Given this list of marker genes Sgta, Ap3m1, Nup155, Cav1, Gsn, Dnm1, Chmp1b2, Ap1s1, Grik5, Doc2a, Yipf5, Trappc11, Rab3gap1, Gorasp2, Tmem147, Usp50, Vti1b, Sptbn5, Rims2, Lysmd3, Spata46, Bin3, Mtss1, Tor1a, Plscr4, Lyst, Arhgap21, Tmem170, Map2k1, Als2, Yipf4, Trappc8, Atp8b1, Esyt2, Snx3, Spaca1, Golga2, Ncln, Tlcd1, Lnpk, Optn, Cog1 (component of oligomeric golgi complex 1), Tango2, Prkd1, Acrbp, Epb41l3, Ehd3, Pla2g3, Pacsin1, Emc2, Tmem33, Tlcd2, Snx9, Dym, Rfx2, Pi4k2b, Cog7, Plec, Ap5z1, Lamtor1, Gsdmd, Clasp2, Abcd2, Aqp11, Abca7, Vmp1, Gak, Tmem201, Pheta2, Rab1b, Rab8a, Rtn3, Vti1a, Sh3gl2, Rab2b, Washc5, Stx19, Asap1, Serinc3, Vps11, Ndel1, Pals1, Tmf1, Snap47, Sypl2, Plscr2, Agfg2, Cul7, Ndrg1, Lmna, Gcc2, Reep2, Garin1b, Mapk3, Tmed7, Atl2, Reep3, Rtn1, Ank2, Prkn, Osbpl2, Fhdc1, Slc35d3, Tmed11, Sqstm1, Tmed5, Stx7, Mia3, Jagn1, Tmprss12, Vdac2, Myrf, Vcpip1 (valosin containing protein (p97)/p47 complex interacting protein 1), Cdk1 (NCBI Gene Id 12534), Abca1, Ap1s3, Polr2m, Cylc1, Tmem41b, Chmp5, Nomo1, Sec31a, Trim72, Chmp1a, Banf1, Myh9, Izumo1r, Myh10, Snx18 (NCBI Gene Id 218636), Tbpl1, Usp8, Bloc1s3, Pde4dip, Cd9, Sppl2c, Ccdc42, Plscr1l1, Spaca5, Bin2, Otof, Vps51, Atp8b5, Nectin2 (nectin cell adhesion molecule 2), Ugcg, Get1, Tmem9, Tmem95, Dmkn, Eif2ak3, Serpine2, Casq1, Lemd2, Ap3d1, Stx5a, Coro7, Syt7, Atg9a, Itga3, Ywhaz, Lpcat3, Ap3b1, Zfyve27, Dcst2, Rab6b, Ccdc38, Llcfc1, Esyt3, Eqtn, Rph3al, Cav3, Arfgef1, Hook1, Prrt2, Arv1, Shtn1, Emc3, Grxcr1, Casp1, Caml, Fam209, Mfsd14a, Vrk1, Cc2d1a, Ank3, Zfp385a, Ier3ip1, Sptbn1, Washc1, Folr2, Cert1, Hyal5, Ptprc, Ap1m1, Fasl (Fas ligand), Mta1, Smpd4, Tjap1, Tardbp, Chmp4b, Fat4, Hook3, Des, Cylc2, Mymk, Als2cl, Tmed6, Dync2h1, Aktip, Huwe1, Lyzl6, Tmem38a, Srgn, Trip11, Frey1, Ubxn2a, Creb1, Pacsin3, Cog8, Atr, Vps13b, Chmp3, Rab30, Myof, Nploc4, Hps5, Fer1l6, Sec16a, Ubl4a, Dmpk, Plekhf1, Vps33b, Glipr1l1, Xkr9, Ano7, Tle6, Spta1, Rab18, Tmed4, Rab3a, Rab2a, Rtn4, Colec12, Spam1, Bhlha15, Stk25, Emc10, Sptb, Golph3, Tie1, Adam1a, Dcaf17, Baiap2l1, Kcne1, Garin4, Blzf1 (basic leucine zipper nuclear factor 1), Agrn, Vamp1, Chn2, Atp10a, Col5a1, Tmed9, Usp6nl, Crb1, Emc4, Surf4, Retreg2 (NCBI Gene Id 227298), Golga5, Vapa, Stxbp1, Hps4, Micall1, AU040320, Mapk15 (mitogen-activated protein kinase 15), Ubxn2b, Ptk2b, Akap9, Osbp, Htt, Tor1aip2, Nemp1, Rab33b, Cav2, Use1, Pten (phosphatase and tensin homolog), Tpst2, Erc2 (ELKS/RAB6-interacting/CAST family member 2), Plekha3, Actl9, Mymx, Chmp6, Degs1l, Sec16b, Retreg1, Rims1, Laptm4b, Stx17, Spaca6, Micall2, Arhgef7, Ar, Steep1, Dnajc13, Synj1, Fbxw8 (F-box and WD-40 domain protein 8), Rab3gap2, Cplx1, Sh3glb1, Clu, Akap8l, Chmp7, Slc4a1, Emc8, Abcd1, Wasl (WASP like actin nucleation promoting factor), Pik3c3, Syt2, S100a10, Atl3, Col6a1, Stx11, Rtn2, Rimbp2, Serinc2, Trappc12, Coro1c, Pi4k2a, Gbf1, Zpbp, Rab1a (RAB1A, member RAS oncogene family), Catsper1, Lyzl4, Bag6, Flot1, Syne1, Cxcr4, Degs1, Anxa8, Ano5, Nsfl1c, Nbeal2, Rph3a, Mtss2, Camsap2, Vapb, Washc4, Rnf26, Rbsn, Snap25, Trpc5, Atg9b, Zw10, Arfgef2, Plk3, Actl7a, Cacna1b, Cplx4, Nup93, Rab10, Tmed10, Hdac3, Ehd2, Zpbp2, Kifc3, Rnf112, Ap1b1, Rab43, Dmtn, Get3, Sptssb, Ap3s2, Xkr6, Cdan1, Armh3, Lmnb1, Psap, Ano9, Syt8, S100a9, Rab29, Emc1, Myo18a, Syt9, Tmed2, Cit, Pdcd10, Cln3, Cog6, Ptbp1 (polypyrimidine tract binding protein 1), Sh3tc2, Stx2, Dysf, Sec31b (SEC31 homolog B, COPII coat complex component), Esyt1, Abcg1, Plekhj1, Trdn, Syt13, Arl6ip1, Dcst1, Pheta1, Stx1a, Garin3, Spink2, Reep5, Ctdnep1, Mafb, Brox, Arl8b, Baiap2l2, Spesp1, Fsip1, Stx12, Fa2h, Cog4, Dnm2, Atp8b4, Cltc (clathrin heavy chain), Hace1, 4930451I11Rik, Snf8, Parp11, Rab11a, Snapin, Casp7 (NCBI Gene Id 12369), Gzmb, Syngr1, Ccdc47, Hikeshi, Reep4, Csrp3, Ccdc136, Slc9a8, Plekhf2, Cog3, Large1, Plk1, Sun1, Hook2, Tram1l1, Snx33, Xkr7, Baiap2, Plscr5, Iqgap1, Xkr8, Spast, Xkr4, Tor1aip1, Lemd3, Garin1a, Snap23, Chmp2b, Tom1, Spaca3, Anxa2, Prf1, Wnk1, Tmed1, Wdr54, Tmem43, Tbc1d20, Exoc8, Emp2, Syt4, Vps4b, Ap1s2, Chmp1b, Tor1b, Atl1, Sec23ip, Camsap3, Vamp4, Plscr3 (phospholipid scramblase 3), Arl1, Rab5b, Cog5, Rnasek, Syt11, Nox1, P2rx7, Dctn1, Ap3s1, Umod, Tmed3, Zbed3, Csnk1a1, Whamm, Tmcc1, Snx10 (NCBI Gene Id 71982), Rab5c, Stx6, Emc7, Mmgt1, Zmpste24, Hps6, Folr1, Tmem127, Gorasp1, Pacsin2, Syngr2, Golph3l, Atp8b3, Clasp1, Pex5, Tram1, Yipf7, Bet1, Doc2g, Sytl4, Baiap3, Tgfb2, Sox30 (SRY (sex determining region Y)-box 30), Akt1, Obsl1, Ankle2, Gper1, Cavin2 (NCBI Gene Id 20324), Pln, Dtnbp1, Xrcc4, Ano6, Sun2, Syt5, Sec22b, Mapk1, Stx1b, Gramd2a, Erc1, Fnbp1l, Atp8b2, Izumo1, Pfn4, Clptm1l, Wdr83os (NCBI Gene Id 414077), Ubr4, Hps1, Emd, Bin1, Tmem38b, Emc9, Plscr1, Stx4a, Agfg1, Rnf26rt, Tmco1, Hid1, Rab22a, Sec61a1, Fhip1b, Ano4, Lman1, Cacna1s, Lmnb2, A4galt, Retreg3, Ap1g1, Bnip1, Lrrk2, Aqp1, Pdcl2, Prmt5, Fam174b (NCBI Gene Id 100038347), Snx19, Reep1, Rilp, Smpd1, Myo5a, Doc2b, Vps4a, Snap29, Nherf1 (NCBI Gene Id 26941), Pafah1b1, Uso1, Rab27a, Syt1, Ilk, Csnk1d, Tram2, Cdc42, Hps3, Poc1b, Plekhm2, Izumo3, Emc6, Bag5, Chmp4c, Sod1, Tmeff2, Rab5if, Akt2, Chmp2a, Cplx3, Get4, Naglu, Cplx2, Atp2a2, Rab38, Ano3, Fer1l5, Stx18, Cog2, Map2k2, Prx, Serinc5, Vps18, Fer1l4, here is a description of the gene set: species: Mus musculus A process that is carried out at the cellular level which results in the assembly, arrangement of constituent parts, or disassembly of the endomembrane system. Mouse Gene Set: GOBP_ENDOMEMBRANE_SYSTEM_ORGANIZATION